The following is a description of a gene set: part of: Mucopolysaccharidoses Mucopolysaccharidosis II (MPS II, Hunter syndrome, MIM:309900) is an X-linked, recessive genetic disorder which therefore primarily affects males. MPS II was first described in 1917, by Major Charles Hunter and is caused by a deficiency (or absence) of iduronate-2-sulfatase (IDS, MIM:300823), which would normally hydrolyse the 2-sulfate groups of the L-iduronate 2-sulfate units of dermatan sulfate, heparan sulfate and heparin. Without IDS, these GAGs accumulate in the body and are excessively excreted in urine. Although the disease was known since the early 1970s, being the first MPS to be defined clinically in humans, it wasn't until the 1990s that IDS was cloned. It is now known to be localized to Xq28 and contain 9 exons spanning approximately 24 kb.<br>Build up can occur in the liver and spleen as well as in the walls and valves of the heart (reduced hepatic and cardiac function, liver/spleen hepatosplenomegaly), airways (leading to obstructive airway disease), all major joints and bones (joint stiffness and skeletal deformities) and in brain (severe mental retardation). The rate of progression and degree of severity of the disorder can be different for each person with MPS II. Severe forms of the disorder can result in death in childhood whereas those with a "milder" form can expect to live to their 20's or 30's. Some patients even survive into their fifth and sixth decades of life. Reactome Pathway: MPS II - Hunter syndrome (HS-GAG degradation) studied in species Homo sapiens, and this is the list of marker genes: IDS